The following is a description of a gene set: Human Gene Set: WP_LEUKOTRIENE_METABOLIC_PATHWAY Leukotriene metabolic pathway species: Homo sapiens, and this is the list of marker genes: DECR2, DPEP2, GGT5, CYP4F3, DECR1, ALOX5AP, ABCC1, LTA4H, DPEP1, LTC4S, GGT1, ALOX5, PTGR1